Given this list of marker genes AP2B1, SAT1, APP, CBX1, SOX4, LGALS3, NREP, CTNNA1, VAMP8, ADD2, S100A10, ALDOC, HSD17B8, DNAJC7, NME1, NET1, FABP5, GSDME, MAP4K4, ECI2, SQOR, GNAI1, RAB4A, LGALS1, IDH2, PKM, ACLY, here is a description of the gene set: Adult T-cell leukemia/lymphoma (ATLL) is a malignancy slowly emerging from human T-cell leukemia virus type 1 (HTLV-I)-infected mature CD4(+) T-cells. To characterize the molecular modifications induced by HTLV-I infection, we compared HTLV-I-infected WE17/10 cells with control cells, using micro-arrays. Many calcium-related genes were progressively downmodulated over a period of 2 years. Infected cells acquired a profound decrease of intracellular calcium levels in response to ionomycin, timely correlated with decreased CD7 expression. Focusing on apoptosis-related genes and their relationship with CD7, we observed an underexpression of most antiapoptotic genes. Western blotting revealed increasing Akt and Bad phosphorylation, timely correlated with CD7 loss. This was shown to be phosphatidylinositol 3-kinase (PI3K)-dependent. Activation of PI3K/Akt induced resistance to the apoptotic effect of interleukin-2 deprivation. We thus propose the following model: HTLV-I infection induces a progressive decrease in CD3 genes expression, which eventually abrogates CD3 expression; loss of CD3 is known to perturb calcium transport. This perturbation correlates with loss of CD7 expression and induction of Akt and Bad phosphorylation via activation of PI3K. The activation of the Akt/Bad pathway generates a progressive resistance to apoptosis, at a time HTLV-I genes expression is silenced, thus avoiding immune surveillance. This could be a major event in the process of the malignant transformation into ATLL. Human Gene Set: AKL_HTLV1_INFECTION_UP species: Homo sapiens Genes up-regulated in WE17/10 cells (CD4+ T lymphocytes) infected by HTLV1 (and thus displaying low CD7) compared to the uninfected (i.e., CD7+) cells. from publication Akl H, Badran BM, Zein NE, Bex F, Sotiriou C, Willard-Gallo KE, Burny A, Martiat P (PMID 17287851)